Given this list of marker genes Cbfb, Ccnd1, here is a description of the gene set: studied in species Mus musculus part of: Transcriptional regulation by RUNX1 This event has been computationally inferred from an event that has been demonstrated in another species.<p>The inference is based on the homology mapping from PANTHER. Briefly, reactions for which all involved PhysicalEntities (in input, output and catalyst) have a mapped orthologue/paralogue (for complexes at least 75% of components must have a mapping) are inferred to the other species. Reactome Pathway: Regulation of RUNX1 Expression and Activity electronically inferred by orthology from the curated human pathway